Given this list of marker genes AMH, WNT4, ZFPM2, FGF9, DMRT1, SRY, PTGDS, GATA4, SOX9, NR5A1, WT1, FOXL2, DHH, here is a description of the gene set: Transcriptional regulation of testis differentiation species: Homo sapiens Human Gene Set: REACTOME_TRANSCRIPTIONAL_REGULATION_OF_TESTIS_DIFFERENTIATION